The following is a description of a gene set: from publication Cui A, Huang T, Li S, Ma A, Pérez JL, Sander C, Keskin DB, Wu CJ, Fraenkel E, Hacohen N (PMID 38057668) Genes negatively differentially expressed in cell type: CD4+ T cell upon treatment with cytokine: IL-21 in mouse lymph nodes in vivo. studied in species Mus musculus Cytokines mediate cell-cell communication in the immune system and represent important therapeutic targets. A myriad of studies have highlighted their central role in immune function, yet we lack a global view of the cellular responses of each immune cell type to each cytokine. To address this gap, the authors created the Immune Dictionary, a compendium of single-cell transcriptomic profiles of more than 17 immune cell types in response to each of 86 cytokines (>1,400 cytokine-cell type combinations) in mouse lymph nodes in vivo. A cytokine-centric view of the dictionary revealed that most cytokines induce highly cell-type-specific responses. For example, the inflammatory cytokine interleukin-1β induces distinct gene programmes in almost every cell type. A cell-type-centric view of the dictionary identified more than 66 cytokine-driven cellular polarization states across immune cell types, including previously uncharacterized states such as an interleukin-18-induced polyfunctional natural killer cell state. Mouse Gene Set: CUI_T_CELL_CD4_IL21_RESPONSE_DN, and this is the list of marker genes: Akap13, Tmsb10, Hspa1a, Hspa1b, Btg2, Tsc22d3, Fos, Uba52, Junb, Klf6, Jun (jun proto-oncogene)